Given this list of marker genes TM9SF4, ERLEC1, EDEM1, SEC16B, SVIP (small VCP interacting protein), CD81, GCC2, CRYZL2P-SEC16B, TMEM30A, UBE2J1, UBAC2, YOD1, SLC51B, DERL2, DERL3, SLC35D3, TMEM30B, UBE2G2, BRSK2, SORL1, BCAP31, OS9, EDEM2, INSIG1, here is a description of the gene set: species: Homo sapiens Human Gene Set: GOBP_REGULATION_OF_PROTEIN_EXIT_FROM_ENDOPLASMIC_RETICULUM Any process that modulates the frequency, rate or extent of the directed movement of proteins from the endoplasmic reticulum.